Given this list of marker genes ANKH, EDNRB, FGFR1, FGF23, ALPL, HNRNPD, PHEX, ABCC6, RUNX2, here is a description of the gene set: studied in species Homo sapiens Any process that results in a change in state or activity of a cell or an organism (in terms of movement, secretion, enzyme production, gene expression, etc.) as a result of a sodium phosphate stimulus. Human Gene Set: GOBP_RESPONSE_TO_SODIUM_PHOSPHATE